Given this list of marker genes Fyn, Mark2, Fes, Rgs2, Dnm1l, Slc30a1, Stmn2, Prkd1, Katnb1, Tmem106b, Arsb, Ppp2r5d, S100a9, Amigo1, Ngfr (NCBI Gene Id 18053), Arhgap35, Mfn1, Abl2, Trim67, Nme1, Baiap2, Marcks, Ankrd27, Ret, Hap1, Hspa5, Nfe2l2, Ntrk2, Cbfa2t2, Ptbp1, Twf1, Ephb2, Ptprd, Igf1r, Ppp2r5b, Cpeb1, Plxnb3, Rapgef2, Atp1b2, Ddx56, Pafah1b1, Pacsin1, Atoh7, Mtor, Fzd1, Itga6, Ltk, Kdm1a, Cntn1, Itga3, Mfn2, Robo3, Crtc1, Tmem30a, Sphk1, Caprin2, Ptk7, Dmd, Ngf, Ube2v2, Ntrk1, Kalrn, Sf3a2, Itpr1, Plppr5, Adamts1, Braf, Ap2a1, Ndrg4, Camk1d, Acsl6, Twf2, Tsc2, Cux2, Wnt5a, Vldlr, Lrp6, Ndel1, Dvl1, Styxl1, Opa1, Ptk2b, Dynlt1c, Ptpn5, Hspb1, Actr2, Apoe, Negr1, Camk1, Met, Itgb1, Fig4, Il6, Mir124a-2, Afdn, Lrrc7, Cd24a, Cobl, Nck1, Stau2, Disc1, Tubb2b, Fgfr1, Cflar, Dynlt1b, Dynlt1f, Kat2b, Enc1 (NCBI Gene Id 13803), P2ry2, Bdnf, Nme2, Rit2, Epha3, Ptn, Cyfip1, Ep300, Bcl11a, Ankrd1, Ddr2, Ddr1, Ptprz1, Adcyap1, P3h1, Nrxn1, Adnp, Ryk, Dpysl3, Pum2, Neu1, Setx, Fez1, Alkal1, Scn1b, Nox1, Ahi1, Snx3, Fbxo38, Fkbp1b, Rrn3, Ikbkb, Nptn, Actr3 (NCBI Gene Id 74117), Tnn, Clip1, Stk24, Alkal2, Reln, Bhlhb9 (NCBI Gene Id 70237), Mapt, Nckipsd, Prkci, Camk2b (calcium/calmodulin-dependent protein kinase II, beta), Dynlt1a, Ndnf, Fut9, Mob2 (MOB kinase activator 2), Scarb2, Tiam1, Plxnb2, Atf1, Pak3, Eef2k, Epo, Dcc, Mir124a-3, Elavl4, Kif3c, Epor, Xlr3b, Iqgap1, Abl1, Zfp804a, Rap1a, Agt, Adam17, Itpka, Retreg3, Cask, Nf1, Htr7, Plk5, Bmp5, Zdhhc15, Dbn1, Lrp1, Tenm3, Dbnl, Pcp4, Bmp7, Lyn (LYN proto-oncogene, Src family tyrosine kinase), Ppp1r9a, Serpinf1, Flna, Il1rapl1, Ezh2, Sirt1, Dhx36, Crp, Mdk, Cx3cl1, Alk, Ntrk3, Lif, Scarf1, Ehd1, Nlgn1, Rapgef1, Nrg1, Caprin1, Tox (NCBI Gene Id 76569), Hnrnpk, Shoc2, Ptk6, Pla2g3, Cntf, Atp8a2, Gprc5b, Kidins220, Apbb1, Ranbp1, Washc5, Qki, Serpini1, Hgf, Magi2, Khdc3, Lrp8, Avil, Creb3l2, Cnr1, Arf6, Cxcl5, Rgma, Mir124a-1, Grn, Gpc2 (NCBI Gene Id 71951), Bmp4, Dab2ip, Serpine2, here is a description of the gene set: Any process that increases the rate, frequency or extent of neuron projection development. Neuron projection development is the process whose specific outcome is the progression of a neuron projection over time, from its formation to the mature structure. A neuron projection is any process extending from a neural cell, such as axons or dendrites (collectively called neurites). studied in species Mus musculus Mouse Gene Set: GOBP_POSITIVE_REGULATION_OF_NEURON_PROJECTION_DEVELOPMENT